Given this list of marker genes LMNB1, UPP1, ST20-AS1, ATG16L2, ATP2B4, CHD1, UBE2R2, AGTPBP1, CCNT1, PLBD1, H2BC4, ARL11, WTAP, VASP, IGSF6, ZNF148 (zinc finger protein 148), SDHAF4 (NCBI Gene Id 135154), STK3, RHOU, RNF19B (ring finger protein 19B), ZBED6, ANKRD13D, RUFY2, S100A8, PDLIM7, CFL1, GPCPD1, KLF10, STOX2, PLPPR2, ABCA1, PAQR9, LINC02724, SLCO3A1, MAFG, GLIPR2, CPEB4, PSENEN, RNF115, FPR1, IER5L, TNFRSF1A, ARL4A, FANCL, LYN, DSE, ZEB2, GAS7, DICER1, RASGRP4, PLEKHM1, ADAMTSL4, P2RX7, RAB27A, GPR84, SESN2, SLC16A6, MALAT1, CLCA2, MED13L, TFE3, H1-6, GATAD2B, PTK2B, ADAP1, LRRFIP1, SESTD1, DAPP1, FCER1G, TLR6, NPL, USP4, MIR101-1, GSR, FGD4, LRRFIP2, TLR5, RAB32, RAB31, AFF1, TMEM119, GNG5, SFRP2, LAPTM5, IGF2BP2, S100A11, RFX2, ABCA2 (ATP binding cassette subfamily A member 2), GDE1, CYP1B1, LIMS3, CERT1, SLC22A4 (solute carrier family 22 member 4), ERP44, GDAP2, BCL3, MIR21, MAPK3, NATD1, CMIP, BMP2K, RBPJ (recombination signal binding protein for immunoglobulin kappa J region), RAB1B, KCNJ2, SBNO2, SMARCD3, SORT1, FCGR1BP, WDFY2, KLF7, FLVCR2, STYK1, TRIM23, C6orf62, ETV6, PRPF38B, CREBRF, CFLAR, CYSTM1, AOAH, SERPINA1, JOSD2, ST3GAL2, NAIP, MAP3K20, KRT8P12, LILRA5, GPATCH2L, ITCH, CREB5, OSTF1, TUBB2A, SNORA28, SERPINB1, EFHD2, RAB5B, JAK2, UBN1, SLC8A1, ITPRIPL2, RCAN2, LILRB2, AP5B1, S100A4, CIMAP1B, YPEL4, VANGL1, ATF7IP, SLPI, GCNT7, SSX5, SNX18, DUSP3, RXRA, ZYX, LILRB1, DMPK, LITAF, SHKBP1, RPL41, TMEM106A, DCUN1D1, HEXA-AS1, CASP5, CHP1, ELANE, TMEM127, CRISP3, GTSE1, RNPC3, RELT, RPS27, PGM5, EGR1, NFIA, IPMK, VPS9D1, VAMP3, STXBP2, UBE2D1, TRIM8, ASAP1, GLUL, PKN2, SH3BGRL3, VCAM1, SPI1, CTSB, ZFP36, S100A9, here is a description of the gene set: Human monocyte derived dendritic cells matured via galectin-1 or LPS. Human Gene Set: GSE4984_UNTREATED_VS_GALECTIN1_TREATED_DC_UP from publication Fulcher JA, Hashimi ST, Levroney EL, Pang M, Gurney KB, Baum LG, Lee B (PMID 16785517) species: Homo sapiens Genes up-regulated in monocyte-derived dendritic cells: control versus treated with LGALS1.